The following is a description of a gene set: species: Homo sapiens Human Gene Set: MEF2D_TARGET_GENES Genes containing one or more binding sites for (MEF2D) in their promoter regions (TSS -1000,+100 bp) as identified by GTRD version 20.06 ChIP-seq harmonization. from publication Yevshin I, Sharipov R, Kolmykov S, Kondrakhin Y, Kolpakov F (PMID 30445619), and this is the list of marker genes: SP2, RN7SKP192, EVA1B, PRELID3A, RPS29, ZNF576, SEPTIN4, TMEM248, LRRC8C, NFATC3, CCNI (cyclin I), RIN3, PRPSAP1, HNRNPD, MIR548AW, PTBP1, PEX3, ZFYVE1, RPS7 (NCBI Gene Id 6201), KAT5, AMN1, BMPR1A, EIF2D, SH3TC2-DT, METTL13, SUGCT-AS1, ACTR3C, TRNAU1AP, PMS2P4, P4HB, BNIP3L, DHFRP2, CDYL, PLA2G12A, ATF7IP2 (activating transcription factor 7 interacting protein 2), ASB8 (ankyrin repeat and SOCS box containing 8), SUCLA2, TCTN1, TIMM50, BMAL1, SDE2, ENSG00000255314, CTNNA2, FBXO4, AQP1, MYLK3, NR1H3, ENSG00000266976, AKT1S1, LINC00635, FAM131A, KCNJ11, EXOSC6, ITFG2, LINC01970, SMCO1, SLC39A9, CEP120, PAK6, ERAP1, IFTAP, KDM5C, LRP6, RPL21P92 (ribosomal protein L21 pseudogene 92), U2AF2, SYCN, MIR3187, CCN1, PURB, ANGPTL4, ZCCHC10, ANGPT1, VMP1, SNHG20, OBSL1, MAP3K7, RPL36P10, C11orf24, SFT2D2, CTNS, ASPH, SNX5, ENSG00000236846, WBP2, WDPCP, SLC38A1, RAPGEF6, IGF2BP3, LINC01132, NRSN2-AS1, TRIM33, ERI1, TEX52, NBPF12, LINC02985, RAD9B, LINC01798 (long intergenic non-protein coding RNA 1798), CMTM3, TMBIM1, ATAD2 (NCBI Gene Id 84325), KCNAB1, AKR1E2, ARHGAP1, PTPN4, HNRNPC (heterogeneous nuclear ribonucleoprotein C), SUMO2, MYO18A, TIAL1, NAGLU, LINC01719, PHF5AP7, NRBF2, ADAT2, CASC3 (CASC3 exon junction complex subunit, NCBI Gene Id 22794), DENND1A, CKB, PCID2, HPN, AMH, ADIPOR2, GOLGA3, HDAC6, UFSP1, HSPB1, DHRSX, CILP, ADGRD1, PEAK1 (NCBI Gene Id 79834), MIR4766, GNA13 (NCBI Gene Id 147219), KCNN1, ILF3, ARHGAP26-IT1, HEATR5A-DT, NEK6, EZH2, ATP2C1, ATP13A3, YWHAH, FAAP20, CCRL2, TRAPPC6A, UBE2O, HDAC7, PTMS, SLC12A8, SLC9A1, LSR, SLC35A5, RNVU1-15, THBS3-AS1, ZNF24, ATP8A2, ILF3-DT, MAST4, EPCIP-AS1, UBR1, UBA5 (ubiquitin like modifier activating enzyme 5), HSPBP1, GGT1, GABARAP, BRSK1, CFLAR-AS1, STXBP5-AS1, WTAP, TOR1A, BUB1 (BUB1 mitotic checkpoint serine/threonine kinase), TAF1D, RNU6-2, SEC24C, LMNA, DEPP1, HJV, SPRED1, HDAC9, ZNF175, CCNL1, LDLRAP1, SPHK1, RN7SL760P, MCAT, MTARC1, RNA5SP324, CALHM5, LAMP1, MEF2D, MOG (NCBI Gene Id 4340), ATG3, HEATR5A, ERH, TBL1X, ENSG00000249236, HCFC1, KBTBD8 (NCBI Gene Id 84541), CNOT1, ABT1P1, HEXA-AS1, TMEM259, MIR7-3, HACD2, DOCK6-AS1, LINC01257, CP, RFX2, GNL3L, VLDLR-AS1, RPS26, HDDC2, GABPB1, LINC02517, SPDL1, NELFE, VWA7 (NCBI Gene Id 80737), SUN3, NKTR, CLPX, DNM2, MBD5, ITGAM, VPS33A, OPLAH, TSC1, MIRLET7IHG, CHD9NB, PDE3B (phosphodiesterase 3B), WDR36, ANXA11, PRICKLE1, HDAC5, EXOSC5, RNU1-19P, KLF6, SULT1A2, SQSTM1, ZFAND5, LEKR1, CCDC124, PYCR1, ZBTB44-DT, MIR3115, PAX6, ENSG00000227706, C19orf38, PRTFDC1, COX16, USP6NL, MGME1, GABPB1-AS1, MRPL53, GNA12 (G protein subunit alpha 12), BMS1P4, LRRC77P, ELAPOR2, ZSCAN31, TMCC2, ENSG00000225656, CREB3L2, JUN-DT, ERCC1, MIR3684, ZNF341, TMEM161B (transmembrane protein 161B), ITGB5, ATL3, KCNH2, AP2S1, PIK3R3, KCTD21-AS1, HBD, PPP1R3D, SUN1, CCR5AS, INHBE, MAP4K3, RNU5A-1, ATF3, SPATA2, RNU6-194P, CPNE2, ASAP3, ZNF513, ACYP1, SDAD1P1, ZCCHC7 (zinc finger CCHC-type containing 7), MYL12A, TRIB1, UBE2B, KIRREL2, NDC1, ATP2B4, TRMT13, CCDC174, MECOM, DZIP1L, ZNF436, ALDH1A2, PRSS23, RPL31, CCDC136, CABIN1, ZBED5-AS1, SEC31B (SEC31 homolog B, COPII coat complex component), ST3GAL2, NR4A1 (nuclear receptor subfamily 4 group A member 1), LRPPRC, NRSN2, BRME1, CREB1, KLF7, RN7SL1, GLT8D1, TRIB3, TRIM38, RPF1, NOSIP, PPM1G, IRGQ (immunity related GTPase Q), SAE1, PLA2G4C, PDE4D, ZNF408, ACBD5, ATP13A3-DT, CLEC16A, MTMR9, MYO18B, UBAP2, FKBP8, TTLL4 (tubulin tyrosine ligase like 4), ZBED5, MYBPHL, BMS1P4-AGAP5, CENPJ, ANKRD34A, NUCKS1P1, NDRG4, PNRC1, RTF1, UBE2V1P4, TTLL12, MAP3K4, CARD8-AS1, NAV1, MADD-AS1, AP3M2, CENPA, ENSG00000266401, RN7SL446P, MARCHF1, BAGE2, SP8, CUL4A, DYNC2I2, ENC1, MARCHF2, APIP, SEC14L1, MKS1, LINC02252, PTPA (NCBI Gene Id 5524), SLC41A1 (NCBI Gene Id 254428), AQR, DUSP22, MEF2C, HROB, RHOB, LSM10, C11orf54 (chromosome 11 open reading frame 54), TPGS1, RNVU1-28, XRRA1, LINC02608, GFY, MAK16, MYLK-AS1, ARID4A, TTC23, TOMM40, MEAF6, ZNF503-AS1, COA6, AHCYL2, MYOM2, GABPA (GA binding protein transcription factor subunit alpha), ABCC3, HNRNPA2B1, MOK, C2CD3, RNU5B-4P, MTSS1, MALSU1, DNAJB2, PCCB, CHPT1, PVT1, NBEAP1, PCBP1-AS1, GTF2IRD1, ZBTB8OS (NCBI Gene Id 339487), SPINK4, IMPACT, PICALM, EZR, TAP1, DRG2, ASF1A, IKBKB-DT, CENPK, RNVU1-26, CRYBG2, LINC03016, GFI1B, STAG3L4, BRWD1, ANKRD40, HMG20A, TBCD, FNBP4, ACP2, LEMD2, ZC3H6, LNX1, NOL8, TCERG1, LINC00933 (NCBI Gene Id 100506874), GPRC5C, GALNT11 (polypeptide N-acetylgalactosaminyltransferase 11), RNU1-108P, BCKDHA, SPG11, TBPL1, SCYL2P1, C3orf86P, PARM1-AS1, SPATS2L (spermatogenesis associated serine rich 2 like), PANK1, SYT12, DHX40, HSPA9, SAMD9L, TRAPPC9, ALPL, TNS3, SCRIB, PHRF1, MIR584, C12orf57, CENPP, METTL25, DAZAP1, ARMH4, EOGT, LINC01287, TBC1D17 (TBC1 domain family member 17), NPL (N-acetylneuraminate pyruvate lyase), BLOC1S3, RNU7-1, PAXBP1, CHD4, BPTF, ODAD1, ENSG00000235480, VPS28 (NCBI Gene Id 51160), IFRD2, GDAP1, MYH7B, TMED1, ZBTB44, TMEM268, ANPEP, RNU6-927P, SNORA32, CCDC59, GNG4, KLHL30, DHRS3, MIR7845, CACYBP, LINC01215, TRABD2A, MAPK6, DOCK6, CNOT7, MRPL48, CC2D1A, ENAM, PKN1, SDHCP3, TXNDC11, FHL3, MIR1284, FSD2, SCYL3, TARS2, MIR5093, RN7SKP114 (NCBI Gene Id 106480868), TSC22D1, MTTP, VDAC2, VPS29, TLR5, TOLLIP, UBE2I, TKT, LNCRNA-IUR, NIFKP7, AP5Z1, AFG2B, TM9SF4, PEX13, RNU6-169P, BCAT1, DNMT3B, KHSRP, NFX1, MIR638, OTUD5, TSSK3, RPL10P7, WBP1L, S100Z, SEPTIN5, MIX23P5, MIR4276, INHA, CHD2, BAX, MYO3B-AS1, BRD3OS, SGCA, HSD17B12, RBBP4, NR4A2, BCAN-AS2, LRRC39, TMEM241, LRRC8C-DT, BZW2, SORD2P, ENGASE, USP48, MIR1205, MID1IP1, RPS14, GYS1, TMEM187, TFAP2A, LINC02015, COMMD10, S100A2, HTR5A, C5orf15, FHL2, FANCA, ATF7IP, PHLPP2, PDS5A, CASD1, MAST4-AS1, FBXL5, AP3S2, GNAS, BCAS3, DACT3, ART1, HUS1, GET4, CLASP1, DGCR8, KNL1, WNK1, ELF2, GLUD1P3, SNORA25, LINC01732, SYNPO2L, EFCAB14, SECISBP2, ELOC, PPFIA4, ATP5PF (NCBI Gene Id 63498), ENSG00000263280, TMEM38B, LEPROTL1, C6orf62, NUP155, ENSG00000206898, CAT, PPP2R5A, SPACA6, KCND2, ALDH5A1, COL4A2, UHMK1, BOD1, TRAPPC2, LRRC28, STRIP1, NAP1L1, MIR4729, JUN (Jun proto-oncogene, AP-1 transcription factor subunit), GBA1, HEXA, PIP4K2A, EFHB, POGZ, SRRM5, PIAS1, MADD, SLC8B1, PARK7, OFD1, ERBIN, DDX3ILA1, PSMB9, MFAP3L, TMEM14B, DHX58, DUS1L, TULP2, B3GAT3P1, ATP6V0CP3, COA6-AS1, FOXK2, PLGRKT, SLC7A8, DACT3-AS1, ADAR, SPAG5, HMGN2P34, LNX1-AS2, MEF2A, RGS20, GAPDHP14, ACTR3B, PTH2, LINC03023, CDKL3, NEK11, USF1, UBE2Q2P1, KDM3A, FCHSD2, CDCA3, CPEB4 (NCBI Gene Id 80315), DDN, PSMA3-AS1, AHI1, BCL9L, GPCPD1, ST7 (NCBI Gene Id 93655), TUBA1B, MIR7-3HG, UTP11, SEMA3C, RPL21P18, PIK3AP1, KLHDC9, ADD1